The following is a description of a gene set: Genes predicted to be targets of miRBase v22 microRNA hsa-miR-7106-3p in miRDB v6.0 with MirTarget v4 prediction scores > 80 (high confidence targets). studied in species Homo sapiens from publication Chen Y, Wang X (PMID 31504780) Human Gene Set: MIR7106_3P, and this is the list of marker genes: PRAMEF4, LDB1, MREG, JPH1, CDC42BPG, SETD5, PRAMEF6, PRAMEF15, KPNA6 (karyopherin subunit alpha 6), EEF2KMT (eukaryotic elongation factor 2 lysine methyltransferase), ITGA3, GNA12, RAPGEFL1, ORMDL3, DDX3X, SHISA9, FBXO42, ANKRD13A, PRAMEF11, EIF4EBP2 (eukaryotic translation initiation factor 4E binding protein 2), PPARGC1B, FAM86B1, BTG2, REEP5, BCAN, NEDD9, RPS6KA1, FAM86C1P, ELAC1, XPO1, KDM2A, PPP1R37 (protein phosphatase 1 regulatory subunit 37), EDAR, TMEFF2, AKAP1, ATXN10, NF2, DTX4, PURA, PRAMEF19, ZDHHC11, KMT5C, USP12, RERE, SSTR2, PRAMEF5, PRAMEF25, NUCKS1